The following is a description of a gene set: part of: Signaling by ERBB4 Reactome Pathway: PI3K events in ERBB4 signaling The CYT1 isoforms of ERBB4 possess a C-tail tyrosine residue that, upon trans-autophosphorylation, serves as a docking site for the p85 alpha subunit of PI3K - PIK3R1. Binding of PIK3R1 to CYT1 isoforms of ERBB4 is followed by recruitment of the p110 catalytic subunit of PI3K (PIK3CA), leading to assembly of an active PI3K complex that converts PIP2 to PIP3 and activates AKT signaling. studied in species Homo sapiens, and this is the list of marker genes: HBEGF, PIK3R1, EREG, PIK3CA, BTC, NRG3, NRG1, NRG4 (neuregulin 4), ERBB4, NRG2